The following is a description of a gene set: from publication Cui A, Huang T, Li S, Ma A, Pérez JL, Sander C, Keskin DB, Wu CJ, Fraenkel E, Hacohen N (PMID 38057668) Genes positively differentially expressed in cell type: Mast cell upon treatment with cytokine: LIGHT in mouse lymph nodes in vivo. Cytokines mediate cell-cell communication in the immune system and represent important therapeutic targets. A myriad of studies have highlighted their central role in immune function, yet we lack a global view of the cellular responses of each immune cell type to each cytokine. To address this gap, the authors created the Immune Dictionary, a compendium of single-cell transcriptomic profiles of more than 17 immune cell types in response to each of 86 cytokines (>1,400 cytokine-cell type combinations) in mouse lymph nodes in vivo. A cytokine-centric view of the dictionary revealed that most cytokines induce highly cell-type-specific responses. For example, the inflammatory cytokine interleukin-1β induces distinct gene programmes in almost every cell type. A cell-type-centric view of the dictionary identified more than 66 cytokine-driven cellular polarization states across immune cell types, including previously uncharacterized states such as an interleukin-18-induced polyfunctional natural killer cell state. Mouse Gene Set: CUI_MAST_CELL_LIGHT_RESPONSE_UP species: Mus musculus, and this is the list of marker genes: Ddx23, Adnp2, Fadd, Btbd6, Lig1, Lyrm9, Tnfrsf1b